Given this list of marker genes MIR1271, CRH, LRAT, SLC2A1, RUVBL2, FOXA1, HRH4, RRAGD, CHRNG, EREG, OTUD5, ARHGEF2, TDO2, CYP1A1, ADAM15, VDR, LARGE1, ATP4B, PSCA, ANKRD13C (NCBI Gene Id 81573), STAT5A, ZNF35, ACE, SSTR1, TNS2, DUSP1, POMC, PMVK, COL6A1, RAB8A, SLIT3, PSPH, PHOX2B, TSC2, KCNK2, STXBP1, DUOX2, CPEB2, REN, TACR3, REG3G, RYR3, DUSP10, GNRHR2, TICAM2, SREBF1, CBS, CTR9, TAT, NKX6-1, CYP26B1, TNIP3, SETX, AXL, SMAD3, LILRB2, FASLG, INPP5E, FBLN5, SPHK2, AFG3L2, OTC, WNT7A, IRS2, THBD, UCP1, WT1, PAF1, FLNA, F5, P2RX2, CD6, DEFA3, VGF, NFKBIL1, PDE3A, LCN10, CCDC186, MIR320D2, IGF1, KAT7, KCNMA1, TBX2, ITGA2, MEAK7, EPHA4, OPRM1, PTAFR, TET1, IL18, CYC1, GATA4, NOTCH1, CAD, PRKCB, PPP5C, CAMKK2, AKAP6, HTR2C, CYP26A1, GPX4, ACTN2, NCOR2, TRAF6, GBA1, MC4R, MTCL2, KCNJ11, GYS2, GJD3, MET, SHPK, ANO1, PF4V1, SORBS1, NR4A2, WNT8B, BCL10, PRKCI, MBD5, GDF10, CITED1, CARD9, ABL1, RBP4, EIF2B1, CAV1, LYN, EN1, PLCG2, TRIM25 (tripartite motif containing 25), TNC, CHMP5, PTPN2, NFKBIZ, GALP (NCBI Gene Id 85569), MTOR, CD2AP, PRKCZ, LTK, GLDC, MIR195, RAB31, ADCY1, RPL10A, NOS3, USF2, NEFL, ALPL, PLAA, GRB2, LEP, NOCT, NOX4, GPR27, LPAR1, HMGB2, AKR1C1, GRXCR1, PIK3R1, WNT5A, TRPM2, MT-ND1, PLK3, HAND2, TBX1, CAT, NR4A3, EDN1, MIR146A, ADH7, TPM1, CSHL1, TRAP1, SLC26A5, ABCA2, PTGER1, ZNF16, SMAD2, NR4A1, RNLS, EIF4EBP2, PAX2, C1QTNF12, CD200 (NCBI Gene Id 4345), FCHSD1, MEIOSIN, SELE, ADAM17, PRKCD, SIX1, PDCD1LG2, FKBP1B, DAG1, RORC, CRY1, HTR6, HDAC5, RFX6, PIK3CG, NDUFA13, PTPRN2, TGFB1, IL6, KBTBD2, DHX36, NTRK3, SNRNP70, GPLD1, UNC13B, NLRP7, RDH11, KHK, ACSL1, MAPK3 (NCBI Gene Id 5595), GJA1, MAPK9, GNAI2, OXCT1, RECQL5, FGFR4, GUCD1, ADIPOR1, PARK7, CHRNA6, GHR, IDE, MPC2, HBB, SP1, MAFA, AGER, ZNF703, HADH, SIRPA, PPARA, BGLAP, ARID5A, CCL2, WNT7B, ANGPT2, CA2, UCP2, PTGER2, TRPC6, TESC, CHRNA4, KCNK16, IL24, DGKQ, TSPO, HTR3B, PIP4K2A, APPL2, SLURP2, LPL, HADHA, IRF5, GRB10, CAV3, CPT1A, JUND, EIF4E, AGRP, WNT11, DRD4, APPL1, MIR320E, INPPL1, CEBPA, RXRA, IRAK3, HNRNPD, ECHDC3, STAP1, NFKB2, SFRP1, KCNE1, RAB13, RAB11B, RPS6, RIPK1, H6PD, STAT6, PDE8B, PIK3CA, EXT1, TRPV4, CD274, RARG, MIR15A, CD38, RGS2, GCH1, FOLR2, DEFB131A (NCBI Gene Id 650444), HCN4, CCR5, GATA3, CHRNA9, LRRK2, BCL2, GCKR, SLC2A4, BRCA1, HNF4A, CSF2RB, RASAL2, CRTC3, AKR1C2, PEX14, THBS1, PIK3R3, EIF2B4, CX3CR1, UPRT, CAMK2A, MIR224, CD36, SIK2, GSTCD, HOXA9, PIK3C3, TH, AQP9, NKX2-2, HSP90B1 (NCBI Gene Id 7184), HOMER1 (NCBI Gene Id 9456), WNT3A, NR5A1, CALM3, FABP3, PXN, TRIM6, SCARB1, FAM210B, CLEC7A, NOS2, SLC1A3, CCL7, IL18BP (NCBI Gene Id 10068), TAB2, TAC1, SLC12A6, STAMBPL1, USO1, DDX18, SOS1, ALDH1A2, PPP3CA, HCRT, REG1A, CEACAM1, GDAP2, RAPGEF1, HTR1A, CHRNE, SGCB, POR, CSRP3, AKAP12, NME8 (NME/NM23 family member 8), MIR27B (microRNA 27b), SIDT2, MSN, ACOD1, OTOP1, IL12A, ABCA1, PKD2L1, PALM3, COA8, CRYAA, PPP1R15B, EFTUD2, IL12RB2, ERN1, FGF23, HNRNPA0, FES, EIF6, RGS4 (NCBI Gene Id 5999), CYP11B1, ADCY8, MAPK7, EPM2AIP1, VCAM1, ARPC1B, HLA-DRB1, PRDX1, IRAK1, CAPN2, REG1B, RDH12, LIAS, GPR173, RARRES2, ADCY5, AMBP, PANX1, GRIN1, ASS1, LILRB1, LTF, GLP2R, EIF2S1, MIR320C2, P2RY2, PKLR, F7, KDM6B, RPS6KB1, G6PD, DNMT1, POU4F1, PHEX, TNIP1 (TNFAIP3 interacting protein 1), CDKN2D, SLIT2, CDK1, AHR, RANGAP1, SIN3A, CA9, ENDOG, IGFBP2, GDAP1, NCOA4, ZNF236 (zinc finger protein 236), MIR34A, FBXO32, KLRC4-KLRK1, TRAF2, CHRM5, GCK, GLB1, GPR37L1, CTSD, ZFAND1, SLC2A8, FZD10, ZFP36, RPS3, ANKK1, DPEP1, RAB10, IFNAR1, CHRNB3, CDK5R1, RAF1, MMP15, IGFBP1, TEAD2, GHRHR, TGFBR2, GPIHBP1, PYCARD, STK25, CXCL6, GIPR, SLC5A5, YWHAG, AKR1C3, CELA2A, NHERF1, PRMT5, CDK16, NPR2, ADRB2, NADK (NAD kinase), SLC27A4, NUGGC, MB, SRR, IL36B, ADPRS, TREM2, GATA1, BMI1, NCL, TLR7, NPPA, ABL2, SETD7, LY6S, SLC10A1, GUCA2B, LY6E, SLC9B2, CARM1, P2RX3, INPP5K, TNF, STAT5B, PDX1, MAPK1, CSF2RA, LRP11, GRIN2D, HCN3, GRB14, RGS9, NPTX1 (neuronal pentraxin 1), PLA2G6, GAS6, NDUFAF2, ENSG00000274276, EIF2B5, SLC34A1, S100A14, KCNK10, NFKBIA, NR1H3, CACNG4, PRLH, SNX6, HDAC6, FECH, OPRD1, CHUK, PTGER4, DSG1, KLF7, GSTP1, MYO1C, WNT6, POLB, SLC10A3, RACK1, GH1, METTL21C, HRH3, PLSCR4, MAP2K7, GNB1, ADCY2, ERRFI1, TGM2, CYP19A1, IL1A, PSMD14, RAPGEF2, BCR, IRF3, P2RY12, MTDH, TGFBR1, PCGF2, NONO, LCN2, PKD2, PDPK1, RWDD1, LANCL2, TYR, ROCK1, USP46, MN1, MAP2K4, NUDT15, ADCY3, CPS1, MGARP, RORA, STRA8, FOS, TP53INP1, PPEF2, AQP3, P2RX6, MYB, LIN28A, WNT2, MGST1, FCGR2B, CLDN18, DAPK1, BAIAP2, GJB6, PPP1R1B, LDOC1, FUT7, CD68, ARRB2, NFKBIB, NR0B2, LTA, CACNB1, TYK2, DHH, INS, KLHL22, PDGFB, SULT1A4, PIK3R2, ACER2, SERPINE1, GNG2, SNAI2, LARP1, TP53, CUL7, MIR185, GPR155, PDE2A, LYPD1, FFAR3 (NCBI Gene Id 2865), ESD, AKT1, MMP9, JAK2, GNRHR, ENY2, ERCC6L2, GCNT1, SLC8A1, PPP2CB, BLOC1S6, CMA1 (chymase 1), ACACA, MIR21, HBA1, COL3A1, IFT80, KMO, MAPK8, ABCC9, ERFE, PNPLA3, GSK3A, GNAL, ITPR1, TGFB3, APLP1, DRD5, NLRP1, GNAQ, MIR433, RHOA, TFRC, FGF2, LPIN1, P2RY11, NCOA3, MAP1LC3A, TRIM24, MIR337, FUT1, P2RY4, ZC3H12A, PLSCR3 (NCBI Gene Id 57048), HTRA2, ZBTB7B, CALCRL, SLC6A3, CRYGD (crystallin gamma D), MIR106B, OSBP, PRKCG, XPO1, CYBB, PTPN1, STXBP4, UMODL1, GPX3, FYN, ME1 (NCBI Gene Id 4199), ARNT2, SIRT1, BMP6, DEFA1, ZNF212, SLC38A2, ALDH1A1, KYNU, MIR128-1, RAP1B, AKIRIN2, IL36RN, SCAP, SMPD1, AQP8, TNFRSF1B, HP, PRKD1, CHRNB1, BTK, S100A7, CASP4, MYRF, RAB11FIP2, IL1B (NCBI Gene Id 3553), FOXO1, SLC30A8, IL1F10, INHBB, LEPROTL1, ZNF683, TNFAIP3, GPR21, JAK3, MT-ND4, SLC26A6, GNA11, OPRK1, HOXA11, CFTR, SRSF4, CXCL10, FOXO4, ASXL1, ALK, EPHA5, CEBPB, CRY2, ROCK2, SLC1A2, OSBPL8, PTPN6, TIMELESS, CYP24A1, CD4, BRINP1, WNT5B, IRF8, EPO, PFKL, AVPR1A, LOXL1 (lysyl oxidase like 1), LDLR, VSNL1, APOD, MEST, CD27, AGRN, SAMTOR, CD86, DDIT4, DRD2, ATM, RPL13A, BAD (BCL2 associated agonist of cell death), WNT3, UCN, LRP6, ANKRD1, SELENOT, GPAM, ZFP36L1, PF4, TIFAB, MIR98, FOXC2, PCSK9, CRHR1 (NCBI Gene Id 1394), HAVCR2, FBXO3, EDNRA, USP8, GABBR1, GUCY1B1, RGS10, ATP2B4, FER, PRKAR1A, AGTR1, SOCS2, FOXO3, SSH1, INSR, IRS1, AR, SLC30A10, TRARG1, STX4, BCL11A, TLR2, FDX1, SGK1, DENND4C, EPS8, SMPD3, KLF15, SLC6A4, KANK1, STC2, BIRC2, IGF2R, KCNA5, IFT88, KCNB1 (potassium voltage-gated channel subfamily B member 1), GPRIN3, CCL27, LPIN2, SYAP1, TOP2B, PTGIR, KAT2B, WNT9B, BRINP3, ELAVL1, YAP1 (Yes1 associated transcriptional regulator), UCP3, LCOR, HDAC2, NOD2, RGS8, CHEK2, SMO, HTR3C, ELK1, INSRR, IDO1, PLN, B2M, DSG2, MIR140, MIR133A1, ANKZF1, NFE2L2 (NFE2 like bZIP transcription factor 2), MIR20A, PTK7, CDK4, SNX5, TFAP4, CHRNA2, HES1, IL36A, HTR4, PHC1, CUL3, HOXA10, GPBAR1, BPI, LHCGR, IL10, RELA, DRD1, VAMP2, MIR223, RAD51, ILDR2, LRP5, KAT5, MAN1A1, TLR4, HSF1, ACVR2B, RBX1, USF1, CXCL13, ZNF106, PEX2, EGFR, TREX1 (NCBI Gene Id 82474), POSTN, GRIA1, EDEM2, TWF2, PPP3CB, DNAI1, P2RX1 (NCBI Gene Id 5023), CASR, NFKB1, CFLAR, CRK, EIF4A3, GLRA1, GNA15, BRSK2, ITGAM, BACE1, TRIM41, TMIGD1, CTNNA1, HMGCS2, CLTRN, CRTC2, PALM, IGF1R, BCL2L1, ZBED3, UMOD, WNT9A, PDE3B, ADH5, ALAD, FADD, FBXW8, DNAAF2, PELI1, DDX11, RPS6KA3, LARS1, PDE4B, CCDC62, INSIG1, BSG, CD180 (CD180 molecule), CYP1B1, PTGDR, YES1, ST8SIA2 (ST8 alpha-N-acetyl-neuraminide alpha-2,8-sialyltransferase 2), LGMN, PTPN11, HMOX1, HIF1A, BAK1, HBA2, MIR6869, CD80, CAPN10, CHRM4, MIR320A, NDUFS4, EGLN1, PINK1, PFKFB2, GIP, BLM, OGG1, HOMER2, PRNP, PDCD10, MALT1 (NCBI Gene Id 10892), POU4F2, UCN3, NUDC, PRKN, CLDN3, KLF2 (NCBI Gene Id 51713), RARA, MRC1 (mannose receptor C-type 1), GH2, CCND1, MYOD1, KANK2, UGT3A2, GLRA2, TNIP2, GATA6, AVP, MAPKAP1, PRDX5, UBR1, C2CD5, ADCY6, OVCA2, GSK3B, GHRL, P2RX7, TLR6, PTPRE (protein tyrosine phosphatase receptor type E), GPR68, CNR2, CCNA2, ATP1A1, SMYD3, CHRNA3, PIM3 (NCBI Gene Id 415116), MIRLET7B, FBN1, PTPRJ, CDK5, HYAL1, CDK2, MAP3K5, ESR1, NEUROD1, VWA2, CHRNB4, ATP5PO, GPER1, TUBA1A, ZDHHC7 (zinc finger DHHC-type palmitoyltransferase 7), RLIG1, KLF9, ATP1A3, GPRC6A, SRI, EDNRB, AIFM1, LY96, NAGK, CASTOR2, FFAR1, CYP7A1, AHCYL1, PLA2G2A, NPAS4, ACP5, PRKAA1, MSTN (myostatin), SIGIRR, SOX9, CDC73, GKN2, MIR142, SOX10, FBP1, MIR200A, MIR107, NFE2L1, MMP19, LY6G6D, ACTB, GCLM, STAT3, PTK2B, STAT4, INSIG2, SLC26A3, VPS54, OR51E2, CDKN2A (cyclin dependent kinase inhibitor 2A), FGF19, MAPDA, XRCC1, AGTRAP, PNPT1, DEFB124, KLF4, RIPK2, WNT8A, CEBPE, SLPI, IGFBP5, ADRA2A, CYP27B1, GPX1 (glutathione peroxidase 1), MIR221, ASPH, MYOG, LY6H, DUOX1, HNF1B, GRAMD1B, TRA2B, ADCY7, ACVR1C, HOXD13, COMT, DYNLL1, TRIML2, AMIGO1, JUP, SYK, MIR187, IL10RA (NCBI Gene Id 3587), PTPRK, PDK4, FFAR2, CTSG, HRAS, OGT, BCAR1, MAP2K3, PIP4K2B, JAK1, ALAS1, LEPROT, AGT (angiotensinogen), CMPK2, NR1D1, IGF2, SMARCC1, AREG, SPP1, H2AZ1, PRPF8, BRINP2, XRN1, CALR, NR2F2, HOXA13, TRIM5, TOP1, CARD16, CXCL5, PRKCQ, SHOC2, MPO, APOE, LYNX1, XIAP, RAMP3, HYAL2, SERPINA12, NTRK1, SLC29A1, PARP1, TRERF1, HTR3E, FGFR2, SH2B2 (NCBI Gene Id 10603), MIR96, EFNA5, BNIP3, PTPRC, NCOA2, BTG1, IRAK2, TIMP1, PABPN1, BCAR3, SLC12A3, TNFSF4, NR3C1, EPHB2, MMP13, TRIM72, HLCS, ZBTB20, SHMT1, UBE3A, LRP1, PCK2, GRIN2B, RNF112, RHOB, TMEM161A, HTR3A, PDK2, FABP1, GNB5, SASH1, TRPC3, MIR145, RAP1GDS1, CALCR, DRD3 (dopamine receptor D3), RAPGEF3, UPF1, AICDA, SOCS3, PDXP, FPR2, E2F1, BMP7, CCS (NCBI Gene Id 9973), EPHA3, MMP2, SESN1, HCN1, APP, EP300, RPS6KA2, BTG2, CX3CL1, PCK1, CD40, COLEC12, TBXAS1, TRIB1, UFL1, SBNO2, KCNJ8, MIR320B2, IRAK4, MSX2, MIR379, CYP8B1, PIP4K2C, PHIP, RAB11FIP5, CACNA2D3, MZB1, MICB (MHC class I polypeptide-related sequence B), ITGA4, OXR1, DDR2, HOXB13, GOT1 (glutamic-oxaloacetic transaminase 1), SPIDR, SRC, MTAP, LACRT (lacritin), CHRNB2, PAWR, TCF12, LITAF, SULT1A3, CHRM3, SOCS7, DEFB114, SMAD6, COL6A3, CARD8, CYBA, TGFB2, ABCC1, PPIF, CRTC1, SLC9A1, ADCYAP1R1, AKR1A1, DNMT3A, EIF2B2, COL1A1, IFITM5 (interferon induced transmembrane protein 5), GNAO1, PJVK, DEFA4, ADAMTS13, SOD2, GNRH1, STK39, ABCC8, GNA14, MLC1, AKAP7, GPR37, PEX10, PRKCA, KL, TUNAR, SCNN1G, RAC1, CDK19, SLC39A9, PRKACA, AANAT, CHRND, PDCD4, FXN, CACYBP, SRF, SPON2, AQP2, RPS6KB2, MIR320B1, NPPC, MIR15B, CDH1, TRIM16, KCNQ1, PPBP, DEFB118, CRYAB, NT5E, ZNF277 (zinc finger protein 277), PPARG, SRSF6, SORT1, CTSH, GBP2, CCR7, AHSG, CLDN4, TCF7L2, VCP, CASTOR1, PLEKHA1, CHRM1, DBH, SRD5A1, MIR766, SLC39A14, GRIN2A, APOA2, NDEL1, PEX13, SOS2 (SOS Ras/Rho guanine nucleotide exchange factor 2), NUCKS1, NCF1, RIPK3, MIR16-1, HDAC3, IL13, TOMM70, CAMP, MAPK13, TRPV1, COL18A1, PTK2, PTPRN, MAS1, P2RX4, BLVRB, GHSR, PEX12 (NCBI Gene Id 5193), CSH1, SOD3, CXCL12, TLR9, FOXP1, MED1, KIF18A, TFF1, CDA, TRPM4, SMARCA4, PCNA, PRKAA2, EPRS1, CPEB1, OSR1, CSF3, PTCH1, DNTT (NCBI Gene Id 1791), MIRLET7F1, ROMO1, FOSL2, HOXA2, MMP3, SLC2A2, MMP12, GOT2, APOA4, G6PC1, SELENOW, STC1, JAG1, CBX3, HTR5A, KLRK1, GCGR, SCD, SOCS1, EHMT2, SYBU, RAP1A, CACNA1A, EZH2, MAT2A, CACTIN, FKRP (fukutin related protein), CERS1, WDR83, GCLC, SMARCD1, CES1, CASP3, KCNK4 (NCBI Gene Id 50801), FCAR, CYGB, GNAI1, TRPA1, RPL23, TSHR, MT-ND5, HTR2A, OSER1, CTNNB1, SLC1A1, PRDX3, FZD4, OSBPL7, ESR2, SMAD4, MAPT, CHRM2, RAP1BL, CHRNA10, ADH4 (alcohol dehydrogenase 4 (class II), pi polypeptide), HCK, AKT2, MDM2, HPGD, ERCC6, SMARCB1, PER1, NOD1, OXT, DGAT2, AKAP9, PDGFD, ZBED6, ABCB1, P2RY1, LBP, TICAM1, SELENOS, AXIN2, DEFB104B, GRB7, BECN1, SCGB1A1, ENPP1, EIF2B3 (eukaryotic translation initiation factor 2B subunit gamma), KCNC2, NKX3-1 (NCBI Gene Id 4824), SCIMP, LIPA, CDC6, ZNF580, CSN1S1, EDEM3, CD55, IL2, CASP1, PIM1, MTHFR, FMO1, SRSF5 (serine and arginine rich splicing factor 5), ERBIN, LETMD1, SLC12A7, JAGN1, PTGFR, ABHD2, GRAMD1C, SPI1, DMTN, MAP1B, NOS1 (nitric oxide synthase 1), SLC8A3, GIT1, MAPK14, LY86, AGTR2, CSH2, PIH1D1, CASP9, AP3S1, SLC27A1 (NCBI Gene Id 376497), MIR182, CD14, LRP8, GDF15, NASP, ADNP, APC, PID1, CYP11A1, PRKDC, BAIAP3, NAMPT, CLDN5, CXCL9, CCNB1, C2, FAM114A1, NLRP3, SCNN1A, CRKL, C6orf89, MMP8, MIR342, PRMT1, ABAT, RORB, GFI1 (growth factor independent 1 transcriptional repressor), ATP7A, PKM, PDE4D, MIR17, TACR1, STRN3, NQO1, FAM3A, SSTR2, PDK3, DEFA1B, RBM4 (RNA binding motif protein 4), CRHBP, PSEN1, STAT1, PPARD, GBP3, PLA2G1B, ATP2B1, KLF16, IL36G, SERPINF1, GATA5, EGR1, NET1, DEFB104A, MBD4, ACTC1, WNT10B, EFNB2, VIM, CBL, HCN2, ENO2, MIRLET7G, DKK1, WBP2, STXBP3, CNGA3, F2R, TAF1, EEF1B2, ADAM9 (NCBI Gene Id 8754), WDTC1, MKKS, CDT1, LONP1, GKAP1, GPR82, MGST2, SIPA1, SHC1, TYROBP, CHRNA7 (NCBI Gene Id 1139), SPHK1, SELP, SLC2A5, FIS1, SP100 (NCBI Gene Id 6672), GPD1, DMAP1, CAV2, MAP3K7, KDM1A, TGFBR3, DTNBP1, PPP1R9B, MBD2, TMBIM6, SCNN1D, WNT1, SCX, ABCA12, MIF, CCL28 (C-C motif chemokine ligand 28), GAB1, UBTF, FOXA2, MTR, CARD17P, TLR5, TXN, ASCL1, LGALS9, FOLR1, MYO5A, HPCA, RXRB, GRIN3A, C14orf28, TIE1, EZR, ACHE (acetylcholinesterase (Yt blood group)), CASTOR3P, MEF2C, NAGLU, SESN2, CACNA1B, P2RX5, CLDN1, LTA4H, MT3, NR1H4, CD96, MT-CYB, SORL1, ADIPOQ, CRHR2, TRIB3, MBD3, SNCA, IGFBP7, ILDR1, CREB1, AKR1B10, SOD1, IL23R, MIR103A1, BOLA3, SESN3, IP6K2, PRDX2, SLC7A5, DYNAP, HGF, MAP4K1, KPNA4, MPV17, IL37, GRAMD1A, AKAP8, EXTL3, FOSB, CXCL8, FAT1, TXNIP, GRM5, FZD7, ITGB3 (integrin subunit beta 3), GABRB1, EEF2K, MIR143, RETN, SCNN1B, TXNRD2, ATP1A2 (ATPase Na+/K+ transporting subunit alpha 2), TSC1 (TSC complex subunit 1), IHH, MIR320D1, RB1 (RB transcriptional corepressor 1), SLC23A2, HTR3D, PENK, MAPKAPK3, INAVA, PAK1, DEFA6, RHOQ, EEF2, SCN11A, ITPR2, BORCS7, DAB2IP, SARM1, S100A8, C2CD2L, CA3, PLEC, DHFR, CHRNA1, AARD, SNW1, REG3A, CSK, CCL3, PRKCE (NCBI Gene Id 5581), IL18RAP, VPS35, PPM1E, GNAS (GNAS complex locus), MIR125B1, VPS13C, INHBA, LPIN3, CBX8, PHPT1, TRPM5, MYD88, CASP8, SRD5A2, MIR92A1, GLUL, BDKRB1, COL6A2, C5AR1, ELANE, CCL19, ZNF592, SLC25A33, RET, ECT2, NCK1, UBR2, SH3RF1, CASP7, HSD11B2, ABCB4, BCHE, SP7, SDK1, P2RY6, HSP90AA1, AQP1, HTR7, PTK6, SOX4, SLC24A4 (NCBI Gene Id 56796), XBP1, TNFRSF11A (TNF receptor superfamily member 11a), NGFR, HADHB, ATP5F1A (NCBI Gene Id 502), CYP11B2, CCL21, RPTOR, GRM2, CSF2, FGF10, SDF4, IRS4, CDO1, AGAP3, TBC1D4, CFL1, FKBP5, DHFRP1, TPCN2, FOXP3, NRIP1, NCOA1, GBP5, MIR200C, IRGM, HSD17B2, DIO2, PTPN22, SLC22A12, GRK2, PLCB1, LILRA2, STAT2, HDAC9, GPI, AKR1C4, TBXA2R, GOLPH3, PITX3, PTGDR2, HID1 (NCBI Gene Id 80791), PIK3C2A, ID3, MLXIPL, HMGB1, HTR2B, DEFA5, PEX5, IL12B, CHRNA5, SLC11A1, MIR320C1, MAPKAPK2, CIB2, GAL, CACNA2D1, NCOA5, RMI1, NCSTN, TIRAP, GCG, PDGFRA, ICAM1 (intercellular adhesion molecule 1), PTH, GLP1R, here is a description of the gene set: studied in species Homo sapiens Human Gene Set: GOBP_RESPONSE_TO_OXYGEN_CONTAINING_COMPOUND Any process that results in a change in state or activity of a cell or an organism (in terms of movement, secretion, enzyme production, gene expression, etc.) as a result of an oxygen-containing compound stimulus.